Given this list of marker genes RNVU1-4, HNRNPA1, PRPF39, HNRNPL, TARDBP, EP300, RNVU1-17, RBM41, U2AF2, RNU2-1, RNVU1-2A, TRA2B, RBM24, SOX9, SLU7 (NCBI Gene Id 10569), U2AF1L4, RNU11, RBM7, ZRSR2, SRSF6, CELF5, SLBP, U2AF1, RBM22, ELAVL4, CELF3, RNVU1-1, DDX5, RNU1-4, RNVU1-6, PRPF8, SNRPC, RNVU1-7, RNVU1-8 (NCBI Gene Id 101447996), PTBP1 (NCBI Gene Id 63477), RNU4ATAC, ARGLU1, ZC3H14, TARBP2, ZRSR2P1, WEE2-AS1, ERI1, TAF12-DT, RBM20, RNPC3, RNVU1-3, CELF1, RNVU1-15, HNRNPU, RBPMS, CELF4, RNU6ATAC (RNA, U6atac small nuclear), SRSF3, RBM4, RNVU1-14 (RNA, variant U1 small nuclear 14), CELF2, RNVU1-19, here is a description of the gene set: species: Homo sapiens Binding to a pre-messenger RNA (pre-mRNA), an intermediate molecule between DNA and protein that may contain introns and, at least in part, encodes one or more proteins. Introns are removed from pre-mRNA to form a mRNA molecule. Human Gene Set: GOMF_PRE_MRNA_BINDING